The following is a description of a gene set: Genes down-regulated in CD4 T helper cells (30h): Th0 versus TGFB1 and IL6. Human Gene Set: GSE43955_TH0_VS_TGFB_IL6_TH17_ACT_CD4_TCELL_30H_DN species: Homo sapiens Despite their enormous importance, the molecular circuits that control the differentiation of Th17 cells remain largely unknown. Recent studies have reconstructed regulatory networks in mammalian cells, but have focused on short-term responses and relied on perturbation approaches that cannot be applied to primary T cells. Here, we develop a systematic strategy – combining transcriptional profiling at high temporal resolution, novel computational algorithms, and innovative nanowire-based tools for performing gene perturbations in primary T cells – to derive and experimentally validate a temporal model of the dynamic regulatory network that controls Th17 differentiation. The network is arranged into two self-reinforcing and mutually antagonistic modules that either suppress or promote Th17 differentiation. The two modules contain 12 novel regulators with no previous implication in Th17 differentiation, which may be essential to maintain the appropriate balance of Th17 and other CD4+ T cell subsets. Overall, our study identifies and validates 39 regulatory factors that are embedded within a comprehensive temporal network and identifies novel drug targets and organizational principles for the differentiation of Th17 cells. from publication Yosef N, Shalek AK, Gaublomme JT, Jin H, Lee Y, Awasthi A, Wu C, Karwacz K, Xiao S, Jorgolli M, Gennert D, Satija R, Shakya A, Lu DY, Trombetta JJ, Pillai MR, Ratcliffe PJ, Coleman ML, Bix M, Tantin D, Park H, Kuchroo VK, Regev A (PMID 23467089), and this is the list of marker genes: RARS1, UTP14A, PTER, SQSTM1, CEBPZ, PGK2, SULT4A1, CDK1 (NCBI Gene Id 983), RAC3, EVI2A, ORC2, COX16, GABARAPL2, ANKRD11, RELB, SIX1, ZZZ3, TRIM13, CLPX, IL1RAP, EQTN, NFIA, TRADD (TNFRSF1A associated via death domain), DNAJA3, ALAS1, TMEM176A, DUSP1, BLTP3A, AVPR1A, RYK, TULP2, TWF2, PGLYRP1, DDX6, METTL26, HDHD5, TSSK1B, CCKAR, TNFAIP2, MRM3, SLC25A4, MYBPC3, COX6A1, TRAPPC2L, COPRS, CAPZB, SF3B5, PEA15, FXYD5, TNFRSF1B, DTD1, RARS2, CXCL2 (NCBI Gene Id 2920), AXIN1, SLC7A8, SIPA1L2, HCLS1, ATP6V0E1, TRIM37, ZNF532, DNAJC13, SRA1, RECQL5, MAGEH1, TNFRSF8, PLXND1, HSD17B11, CDKN2A, MRPS10, ERBB3, USP29, PTDSS2, HPD, GCH1, TOMM70, PIM2, IFIT1B, NME3, C19orf73, RNF19A, TCP10L, PRR15, PLK4, NDUFA4, PLOD3, MPDU1, MLH1, CARD19, CTC1, RSRP1, KIF20A, RNF19B, ACTN2, BCL2L11, MRPS7, MRPL16, ELOF1, CPSF2, DICER1, CD52, TTC1, LONP1, PSMB6, NSMF, PLTP, CHIA, RBM22, PAX5, GNAI1, FOXB1, GDI1, KIF5C, ARID3B, CEBPG, TXNIP, CD3G, COMMD4, LY9, SCRG1, FOXN2, PRG3, SERPINC1 (NCBI Gene Id 462), BTC, MARCHF6, PLAT, TBXAS1 (thromboxane A synthase 1), ANAPC4, LSR, ZNF146, IRF7, ARMC10, SIRT3, IDO1, COL7A1, SBF2, CCNG2, IL1B, PMM2, VAMP2, NAPSA, ZNF467, DPM3, TNFAIP8L1, CSF2, TRAFD1, DGUOK, CDC42EP4, CD83, AURKAIP1, S1PR4, WDR20, CCN3, BCL2A1, CD8A, MTMR14, RPL7L1, EIF3D, GJA3, VPREB1, PDE6D, PTPN21, VPS37C, CSRP3, ZC3H12C, NUP93, DNAJC17, TEAD1, SPTAN1, BCL6, POLR1H, KLF10, CBR1, ITGA8, KIAA0319L, GABARAP, TMPRSS2, PRPF38B, AGTR2, BTK, ST3GAL5, CBX4, THOP1, PBDC1, TNF, KRT1, RGL2 (NCBI Gene Id 9264), CAND1 (NCBI Gene Id 55832), LLGL2, DUSP2, ZBTB16, DUSP8, UBE2L3, SLC6A8 (NCBI Gene Id 6535), EMP3, UROS, RABGGTA, RIN2, COLQ, RRM1, PSMA7